Given this list of marker genes TMED8, CDC45, HOOK3, ESPL1, PIK3AP1, LRP8, KHK (ketohexokinase), STIL, TMEM65, GPR183, NEK2, LOX, FURIN, CPT1C, ZCRB1, OIP5, MRPS18C, UBE2T, MAP3K5, TRIP6, UBE2L6, ERCC6L, SPC24, CPSF1, NHSL3, SESN3, AFP, U2AF1, OLFML3, FAM217B, AKR1B15, CNTLN, CD109, SYCE2, TFDP1, RAD54L, CDC6, FBLN2, AOAH, LARS2, CX3CR1, AURKA, TRIM21, NEK3, IQCB1, HSD17B7, PPIA, SSX2IP, PXK, FASTKD3, ATAD5, GLIS3, MFNG, MMP14, CCDC91, NEDD8, NISCH, NELFE, POLE, PRPSAP1, SGO1, KIF24, COQ6, SLC25A15, SVIP, LBX2, SRBD1, HNRNPA1, AP1G2 (adaptor related protein complex 1 subunit gamma 2), EIF4EBP2, GPX3, BIN1, SERPINH1, BORCS7, PPP1R13B, UBE2L3 (ubiquitin conjugating enzyme E2 L3), HECA, ELMO1, ATP8B2, OSBPL1A, TMEM9, VPS33A, CENPO, TNS3, FCHO1, EIF4ENIF1 (NCBI Gene Id 56478), SNX2, TTF2, UBN1, TBC1D14, TAF1D, DCTPP1, TYW3, LMNB1, ALG9, SRGAP3, BLMH, FAM107B, ARHGAP11A, ATP5MF, PALB2, FHOD1 (formin homology 2 domain containing 1), OXCT1, PARVB, NF2, ZCCHC8, HSCB, FOXC2, KNSTRN, HPS4 (NCBI Gene Id 89781), BCL7A, C16orf74, ALS2CL, GSR, STK35, DAD1, HES6, AQP1, NPY, PRIM1, CTSC, TPX2, QRICH1 (glutamine rich 1), ARHGAP33, PCM1, PDP2, BST2, KIRREL1, NFXL1, PAPSS1, APEH, C8orf58, LTBP2, JPT2, SH3BP5L, CRYBG3, CDCA2, ZUP1 (NCBI Gene Id 221302), SLC16A6, DNMT1, MBNL3, IFT81, DUSP7, ABCC1, APOBEC3B, CENPH, MCM4, SNCAIP, ZNF579, ARPIN, CYSLTR1, PELI1 (pellino E3 ubiquitin protein ligase 1), PFKM, RAD51AP1, LYN, TRAF3IP3 (TRAF3 interacting protein 3), RBM3, CEMIP2, HELLS, NIPSNAP1, SLC35C2, CEP20, SAMD4A, PACS1, RBM43, PID1, GGA2, G3BP2, EIF5A2, DPY19L1, SLIRP, CNTRL, DHFR, HOMER3, MTCH1, ARID3B, ZC3H4, GPN1, ZNF367, CENPQ, TYMS, BUB1B, MAF, LOXL2, CENPT, P2RY12, SLC38A10, GCLM, DIP2A, SKIL, ATP8B4, POLH, ZGRF1, C8orf33, FAM234B, NFE2L2, SUCLG2, EBPL, TNNI2, INPP1, here is a description of the gene set: Genes up-regulated in bone marrow-derived macrophages (45 min): IL6 knockout stimulated by IL6 and LPS versus IL10 knockout stimulated by and IL6 and LPS. IL-10 or IL-6 stimulation of control 129xC57BL/6 murine bone marrow derived macrophages in the presence of LPS. We used microarrays to detail the global programme of gene expression changes in response to IL-6 or IL-10 stimulation in the presence of lipopolysaccharide. BMDMs were isolated from control, IL-6-/-, and IL-10-/- mice on a 129XBL/6 mixed background mice and differentiated in the presence of CSF-1 for 6-7 days. Cells were scraped and plated in 6 well plates at 2x10e6/well. Cells were washed with complete DMEM and rested for 1-2 hr before stimulation with combinations of IL-10 (10 ng/ml), IL-6 (2 ng/ml) or LPS (100 ng/ml) for 45 min or 180 mins. Complete biological replicates were performed. Human Gene Set: GSE5589_IL6_KO_VS_IL10_KO_LPS_AND_IL6_STIM_MACROPHAGE_45MIN_UP from publication El Kasmi KC, Holst J, Coffre M, Mielke L, de Pauw A, Lhocine N, Smith AM, Rutschman R, Kaushal D, Shen Y, Suda T, Donnelly RP, Myers MG Jr, Alexander W, Vignali DA, Watowich SS, Ernst M, Hilton DJ, Murray PJ (PMID 17114459) studied in species Homo sapiens